Given this list of marker genes HDAC10, SRM, PAOX, SAT1, SAT2, DHPS, SATL1, AMD1, HDAC6, here is a description of the gene set: Human Gene Set: GOBP_SPERMIDINE_METABOLIC_PROCESS studied in species Homo sapiens The chemical reactions and pathways involving spermidine, N-(3-aminopropyl)-1,4-diaminobutane.